The following is a description of a gene set: from publication Tabula Muris Consortium (PMID 32669714) studied in species Mus musculus Mouse Gene Set: TABULA_MURIS_SENIS_HEART_AND_AORTA_LEUKOCYTE_AGEING, and this is the list of marker genes: Stat3, Cox7a2l, Rps12, C4b, Rps15a, Pirb, Nupr1, Rps27a, Rps25, Rps29, Vsig4, Rpl14, Mpeg1 (macrophage expressed gene 1), S100a6, Snhg8, Cdk2ap2, Rps4x, Rpl10, Il1b, Rps10, Icam1, Ier3 (immediate early response 3), Cd209f, Tns1, Fos, Pnrc1, Zfas1, 2410006H16Rik, Cd209g, Jund, Rps9, Mcl1 (myeloid cell leukemia sequence 1), Acp5, Itgb2, Rpl23a, Nfkbiz, Plek, Hspb1, Lilrb4b, Napsa, Btg1, Rbm3, Rps14, Ms4a6d, Sirpb1c, Igfbp7 (NCBI Gene Id 29817), Rack1, Eef1a1 (eukaryotic translation elongation factor 1 alpha 1), Rpl19, Fabp4, Srgn, Rpl37, Ifitm6, Rps13, Mgst1, Rpl35, Xdh, Rpl5, Pim1, Rpl39, Rps21, Gm6377, Rpl38, Wfdc17, Dusp2, Klf10, Rps19, Rps20, Lmo4, Bgn, Rps7, Rpl37a, Atf4, Fcgr2b, Rps8, Smpdl3a, Ifitm2, Fosl2, Rpl23, Tnfaip2, Ly6a, Nop53 (NCBI Gene Id 98700), Rps11, Socs3, Rps15a-ps6, Ccl8, Lgals3, Gas5, Clec4d (C-type lectin domain family 4, member d), Rpl13a, Junb, Ecm1, Rpl36a, Rps3a1, Ccl7, Zfp36, Rpl35a (NCBI Gene Id 68254), Samsn1, Fau, Rps18, Rpl36, Rpl6, Nfe2l2, Tpt1, Plac9, Ccnl1, Pfdn5, Ninj1, Eef1b2, Rpl22l1, Rps28, Ly6c1, Gda, Metrnl, Anxa1, Cxcl13, Trib1, Rpl9, Klf4, Dcn, Ier5, Nadk, Msrb1, Synj1, Id3, Ccl6, Nr4a1, S100a4, Rps23